Given this list of marker genes Itpr1, Tnnc2, Cln8, Casq1, Ddit3, Comp, Vps35, Kcnj2, Tshz3, Synm, Adrb2, Prkd1, Gaa, Chrng, Nr4a1, Ccdc78, Scn4a, Hsp90aa1, Stac2, Drd3, Diaph2, Chrnb1 (cholinergic receptor nicotinic beta 1 subunit), Col6a1, Chrnd, Dmpk, Gigyf2, Tnni3, Map1a, Dmd, Kbtbd13, Myh8 (NCBI Gene Id 544790), Rps6kb1, Vps54, Tnnt3, Stac3 (NCBI Gene Id 237611), Myh3, Homer1 (homer scaffolding protein 1), Strit1, Myh14, Ascl1, Diaph1, Tnni1, Rcsd1, Tnf, Stac, Tnnc1, Slc8a3, Actn3, Chrna1, Xrcc1, Tnnt1, Selenon, Grcc10, Atp8a2, Tcap, Hipk2, Cacna1a, Vti1a, Nppc, Cav3, Spr, Chrne, Mylk2, Tnni2, Myh7, Atp2a1, Mtor, Rem1, Jsrp1, here is a description of the gene set: species: Mus musculus Mouse Gene Set: GOBP_MULTICELLULAR_ORGANISMAL_MOVEMENT Any physiological process involved in changing the position of a multicellular organism or an anatomical part of a multicellular organism.